The following is a description of a gene set: species: Homo sapiens Human Gene Set: GOBP_GLANDULAR_EPITHELIAL_CELL_DEVELOPMENT The process whose specific outcome is the progression of a glandular epithelial cell over time, from its formation to the mature structure. A glandular epithelial cell is a columnar/cuboidal epithelial cell is a cell found in a two dimensional sheet with a free surface exposed to the lumen of a gland., and this is the list of marker genes: SPDEF, GATA2, RARA, HIF1A, RARB, BHLHA15, RARG, SLC9A4, PGR, FZD5, GPAT4, XBP1 (X-box binding protein 1)